The following is a description of a gene set: Mouse Gene Set: GOBP_HISTONE_MRNA_CATABOLIC_PROCESS The chemical reactions and pathways resulting in the breakdown of histone messenger RNA (mRNA). species: Mus musculus, and this is the list of marker genes: Tut7, Mtpap, Exosc10, Tut4, Tut1, Lsm1, Atm, Xrn1, Ssb, Tent4b (terminal nucleotidyltransferase 4B), Dcp2, Exosc4, Eri1 (exoribonuclease 1), Tent2, Upf1